The following is a description of a gene set: Microarray gene expression profiling is a powerful tool for generating molecular cancer classifications. However, elucidating biological insights from these large data sets has been challenging. Previously, we identified a gene expression-based classification of primary uveal melanomas that accurately predicts metastatic death. Class 1 tumors have a low risk and class 2 tumors a high risk for metastatic death. Here, we used genes that discriminate these tumor classes to identify biological correlates of the aggressive class 2 signature. A search for Gene Ontology categories enriched in our class-discriminating gene list revealed a global down-regulation of neural crest and melanocyte-specific genes and an up-regulation of epithelial genes in class 2 tumors. Correspondingly, class 2 tumors exhibited epithelial features, such as polygonal cell morphology, up-regulation of the epithelial adhesion molecule E-cadherin, colocalization of E-cadherin and beta-catenin to the plasma membrane, and formation of cell-cell adhesions and acinar structures. One of our top class-discriminating genes was the helix-loop-helix inhibitor ID2, which was strongly down-regulated in class 2 tumors. The class 2 phenotype could be recapitulated by eliminating Id2 in cultured class 1 human uveal melanoma cells and in a mouse ocular melanoma model. Id2 seemed to suppress the epithelial-like class 2 phenotype by inhibiting an activator of the E-cadherin promoter. Consequently, Id2 loss triggered up-regulation of E-cadherin, which in turn promoted anchorage-independent cell growth, a likely antecedent to metastasis. These findings reveal new roles for Id2 and E-cadherin in uveal melanoma progression, and they identify potential targets for therapeutic intervention. species: Homo sapiens from publication Onken MD, Ehlers JP, Worley LA, Makita J, Yokota Y, Harbour JW (PMID 16651410) Genes down-regulated in uveal melanoma: class 2 vs class 1 tumors. Human Gene Set: ONKEN_UVEAL_MELANOMA_DN, and this is the list of marker genes: TSPAN14, NR4A3, IL11RA, NUDT3, LAMA4, DALRD3, NONO, EIF2B5, ABHD6, BEX4, MATN2, SDHAF3, CDK2, ZNF148, RNF7, HLTF, KIF3A, ALDH6A1, LZTFL1, ARF4, LPIN1, CBX7, LSM5, ASAH1, GORASP1, LMCD1, CREBL2, SMARCA1, KPNA4, CDH19, GYG2, KAT2B (lysine acetyltransferase 2B), SIK1, WWP2, SCAP (NCBI Gene Id 22937), RPS27A (NCBI Gene Id 6233), ZNF217, UBXN7, FXR1, HACD3, GAS1 (NCBI Gene Id 2619), MTMR14, DDX3X, KCNS3, TJP1, GNG11, NT5DC2, LAMP1, GPR161, BEX1, SLC25A36 (solute carrier family 25 member 36), MFAP2 (microfibril associated protein 2), HMCES, RYBP, NOL7, PTEN, SPRY1, PALLD, SLC41A3, AHCYL2, TBX2, GSTM3, ATP11B, ERP29, NFYC, TOP2B (NCBI Gene Id 7155), DVL3 (NCBI Gene Id 1857), RABGGTB, RPS9 (NCBI Gene Id 6203), PIWIL1, RYR1, COPA, TGOLN2, OSBPL2, M6PR, ATG3, ENTPD6, HNMT, CREG1, YIPF5, PDGFD, CFAP44, GLB1, FSTL3, CRTAP, CRBN, SCARB2, NRIP1, JAM3, AKR7A2, ARL8B, LSM3, ENTPD1, PLSCR1, GNAI1, PPT2, CEP15, SNRPN, CAV1, OGA, PIK3R1, ERC1, ATP6V1A, NEK4, DPP6, SNHG32, SYBU, SEC62, IMPDH2, KLHL21, RIOX2, CETN2, SORBS1, ARMT1, TLR1 (toll like receptor 1), CTNNBIP1, C4orf19 (chromosome 4 open reading frame 19), GALC, NRP2, MBTPS1, DNAJC4, PDE4D, SMARCC1, PRKCI, ADRB2, DYNC2H1, RHOBTB3, SIRPAP1, TIPARP (TCDD inducible poly(ADP-ribose) polymerase), FAM3C, GCA, MATCAP2, NDUFB4, MCAM, NAP1L2, ENPP2 (ectonucleotide pyrophosphatase/phosphodiesterase 2), RAB17, DPYSL2, EMCN, CSNK2A2, PDGFC, CD200, ERBB3, ITM2A, SERBP1, CD44, ARL2, CIRBP, NMRK2, MARCKS, SDC4, EIF2D, TOM1L1, RPL3, RPL23, RPL24, PDHB (NCBI Gene Id 5162), NOCT, PIK3R4, CMTM6, PEX6, ANAPC5, NDUFAF3, GNAS, DCT, SLC25A38, RPS8 (ribosomal protein S8), ZNF91, RPL22, MAPRE1, LYRM4, QARS1, TOMM70, CUTA, ARPC4, ST3GAL6, CEP57, NEDD9, EDNRB, LSG1, SYNM, HNRNPA1P3 (heterogeneous nuclear ribonucleoprotein A1 pseudogene 3), SOS2, ZNF185, SLC35D2, RSL24D1, PMEL, RPL18A, KLHL24 (NCBI Gene Id 79965), CPS1, AZGP1, DPY19L2P2, IL12RB2, NIPSNAP1, SS18, KLF5, CPN1, CHMP2B, ARMCX2, TOX4, RPL29P5, MEST, SPIN1, SLC6A15, NUDT21, RPL15, UMPS, PCNP, IPO5, TFAP2A, MTUS1, TOMM20, PRKCH, PDCD10, RPL14, EIF4B, PLA1A, LAMB2, SAMM50, DBP, ZSCAN12 (NCBI Gene Id 9753), PBX1 (NCBI Gene Id 5087), ID2, FBL, BFAR, RAF1, RAB6B, AGPAT2, SPP1 (NCBI Gene Id 6696), LRRC8D, UQCRC1, GLUL, ACP5, PEX5, MED21, RHOA, SETD2, WAC, PARL, APOE, HAUS4, GMDS, POSTN, RAB7A, BTG1, RPS14, RPL27AP, PRKAR1A, ETHE1, LPAR6, DFFA, KCNE4, NFE2L1, TESK1, ALDH1L1, SLC35A5, BAMBI, RPL29P7, IFT57, MANSC1, FYCO1, MCM2, ADH5, RPSAP20, CTH, PREPL, TYR, ZNF544, LRRC1, TDRD3, EIF4G1, SSBP2, SIRPA, DNAJA2, CTSF, DDOST, ING3, TPP1, RABGAP1L, PLOD2, PPP1R3C, SLC16A1, OSBPL10, ZBED1, SATB1, SECISBP2L, EPM2A, RARB, PRCP, SOX9, NSG1, TRIP6, GLCE, KIN, NARS2, FOXO3, ABLIM1, PEG10, ZNF22, SNAP23, SLC25A6, MAGEH1, SCAMP1, EIF1B, BRCC3, TXNIP, ETV5, H1-10, DAG1, ECSIT, AIP (NCBI Gene Id 9049), CCNB1IP1, HNRNPDL, DSTN, GTPBP8, PMP22, LETMD1, VAMP3, LARS2, CCDC51, DMD, DEGS1, CAV2, AP2M1, NFIA, SNRK, RPL36AL, GSTM1, SOBP, RPL10A, CTNNB1, DLC1, PTP4A2, KLHDC3, GPR153, TRIOBP, SERP1, DUSP3, FZD6, ZBTB38, NAP1L1, RPL35A (NCBI Gene Id 6165), ETV1, GAPDHS, GMPS, GNB1, FARS2, SPRY2 (NCBI Gene Id 10253), KLF11, HYAL2, COBLL1, MBD4 (methyl-CpG binding domain 4, DNA glycosylase), ATP5MG, ZNF593, COX7A2L, TJP2, RPSA, MASP1, HSPD1, CAND2 (NCBI Gene Id 23066), TWF1, BBX, MLF1, BAG5, PXDC1, TMEFF1, ADD3, CGGBP1, EFEMP2, PIK3CA, RPL11, SEC11A, PEPD, DAZAP2, NAA50, PGD, COX6A2, RPL28, DAB2, BMI1, ALDH9A1, CXADR, SLC39A6, RPS10P5, ANKRD42-DT, VPS51, FDFT1, HEMK1, UBL3 (ubiquitin like 3), HADHA, ZNF532, YLPM1, PLSCR4, ZMAT3, XPC, PSD3, KANK2, H1-2, PCLO, CARTPT, OARD1, ST13, RPL15P22, KDM6A, PDE4B, USP46, NFIB, KDM5B, CSDE1, CTDSP2, SERPINB6, NHERF1 (NHERF family PDZ scaffold protein 1), RPL32, NCKIPSD, CCND1, ATXN7, HSP90AB1, PCOLCE2, CADPS2, TSPAN6, ROPN1, SERPINB9, RMND5A, CAPN7, ZNF423, TBL1XR1, TSPYL1, NMD3, GABARAPL1, FHL2, NPM1, TKT, TUSC3, EIF1AX (eukaryotic translation initiation factor 1A X-linked), WDR1, RNF13, ZDHHC3 (NCBI Gene Id 57245), TXNDC5, HACD2, TIMP3, MBNL2, SERPINI1, NMT2, ZNF415, RIOK3, H2AC6, ROBO1, RPS5, SEMA6A, DLG1, DUSP22, ZBTB20, PLIN2, PRKACB (NCBI Gene Id 5567), FYN, RRAGD, PPP2R5D (protein phosphatase 2 regulatory subunit B'delta), HDAC9, CD83, CCDC28A, SPAG16, PMM1, APPL1 (NCBI Gene Id 26060), PTP4A1, ZSCAN18 (NCBI Gene Id 65982), TMEM97, SNCA, RAB11FIP1, GYPC, LTA4H, FAM184A, RNASE4, NIBAN1, IP6K1, RSL1D1, RPL13, PLAAT1, GPR37, NKTR, PDCD4, TEX41, NDUFB5, HSPA2, USP4, PRPF4, CSGALNACT1, EIF4A2, CDV3, TMEM47, ITPKB, RPL29, HFE, ARL1, VWA5A, ACAA1, EIF3G (NCBI Gene Id 9606), MPPED2, MZT2B, ATP13A3, RPL10P2, CAPRIN1, MRPS18B, SLC35A3, NDN, SLC3A1, CCNG2, POLR1D, EIF3L, TLR4, HSD17B8, ID4, SEC14L5, RPL31, VAMP8, GOLGA4, GMPR2, FAHD2A, RPL5, CNBP, RAB4A, TUBB4A, CNN3, MID2, ZC3H13, GPD1L, TWNK, BSG, H2AZ1, MBNL1, HBB, GSTP1, TRAK1, ADCY6